Given this list of marker genes Chaer1, Pde9a, Rps6kb1, Scn5a, Tnnt1, Nos3, Ep300, Hdac4, Casq1, Slc9a1, Myog, Tnnc1, Foxo3, Gata6, Mtpn, Tomm70a, Rock1, Nr4a3, P2rx4, Errfi1, Becn1, Twf1, Foxp1, Gsn, Adra1a, Pin1, Pparg, Bmp2, Selenon, Dag1, Sgca, Gtf2ird1, Nr3c1, Gdf1, Mtmr4, Parp1, Myoz2, Hamp2, Oga, Mlip, Ndufs4, Ece1, Nfatc3, Camta2, Trim63, Tead1, Notch1, Trip10, Sirt1, Rock2, Ccn4, Cflar, Ppp3ca, Pi16, Myh7, Prkca, Bmp10, Hey2, Adcy10, Nfatc1, Myod1, Ezh2, Myoc, Pak1, Adrb1, Dmd (dystrophin, muscular dystrophy), Ptk2, Foxo1, Camk2d, Trpc3, Mef2a, Nol3, Kdm4a, Smad1, Tnni1, Gatm, Tnfrsf1b, Gata5, Klf15, Tbce, Tcap, Myh6, Asb2, Rgs4, G6pd2, Cav3, Ctdp1, Cmya5, Fdps, Rbm10, Ppara, Zfp418, Gsk3a, Bmp4, Hand2, Klf4, Nppa, Myoz1, Jarid2, Lmna, Gata4, Srl, Hamp, Mtor, Atp2b4, Pin1rt1, Gsk3b, Igfbp5, Mir208b, Aif1, Mef2c, G6pdx, Rgs2, Ar, Agt, Ddx39b, Parp2, Acta1, Mymk, Glrx3, Inpp5f, Yy1 (YY1 transcription factor), Adk, Slc25a4, Nppb, Tnfrsf1a, Fbxo32 (NCBI Gene Id 67731), Pde5a, Smad4, Cdk9, Akap1, Igf1, Akap6, Actn3 (NCBI Gene Id 11474), Prkag3, Smad3, Gtf2ird2, Stub1, Acacb, Kcnn4, Cyba, Mstn, Atp2a2, Edn1, Cacna1s, Lmcd1, here is a description of the gene set: species: Mus musculus A process in which muscle adapts, with consequent modifications to structural and/or functional phenotypes, in response to a stimulus. Stimuli include contractile activity, loading conditions, substrate supply, and environmental factors. These adaptive events occur in both muscle fibers and associated structures (motoneurons and capillaries), and they involve alterations in regulatory mechanisms, contractile properties and metabolic capacities. Mouse Gene Set: GOBP_MUSCLE_ADAPTATION